The following is a description of a gene set: Genes predicted to be targets of miRBase v22 microRNA mmu_miR_5123 in miRDB v6.0 with MirTarget v4 prediction scores > 80 (high confidence targets). Mouse Gene Set: MIR_5123 from publication Chen Y, Wang X (PMID 31504780) species: Mus musculus, and this is the list of marker genes: Commd2, Thumpd3, Ambra1, Krtap5-3, Cert1, Sh2d4a, Fzd7, Ildr2 (immunoglobulin-like domain containing receptor 2), Otx1, Lrfn5, Bcs1l, Gm7073, Zmynd8, Cat, Ilf3, Eif4enif1, Tcl1b2, Klf4, Usp9x, Mapt, Rnf225, Evi2b, Kcnj1, Lrp11, Car8, Hnrnpr, Tmem263, Fgf20, Tcl1b1, Foxq1, Dpp7, Zfp512b, Fasl, Adtrp, Cd226